Given this list of marker genes CDX2, MET, SOX13, CANT1, HNRNPD, RHOF, CTSE, USP3-AS1, SPAG9, ADAMTS5, USH1C, TNNC1, KLK6, SFXN3, KLK1 (kallikrein 1), FBXO2, MSH5, RBMS2 (RNA binding motif single stranded interacting protein 2), CUL4A, TSPAN8 (NCBI Gene Id 7103), RIT1, KCNQ1, ADORA1 (NCBI Gene Id 134), NAGLU, KIFC2, CLDN3, RAPH1, PACSIN2, MYH14, HSPG2, CDK13, MSLN, SIGIRR, TGFBR2, MYO1A, PPL (periplakin), RNF213, BIN1, FOLR1, IER3, CYSLTR1, PRSS3, OGFR, HECTD1, EPOR, IRF8 (NCBI Gene Id 3394), IFNGR1, NECTIN2, WNK1, ZNF814, ZFPM1, LIMK1, BOLA1, DDC, ID1, ARHGAP26, VASP, MSTN, CHRM1, UBE2G2, MLXIP, KLF13, SHB, CDK18, NASP, RBM5, PAPSS2, CAMK2G (calcium/calmodulin dependent protein kinase II gamma), MYO18A, PRSS8, DAPP1, KRT13, CCL15, ARRB2, ATRX, SEMA4G, SOX9, VSIR, DMPK, PGF, ITGB4, GSE1, EVI2A, ARL4C (ADP ribosylation factor like GTPase 4C), POU3F1, STK17B, EREG, RNU6-37P, KLF2, SULT1A3, RRBP1, TNFSF15, FSCN1, MED6, CLDN2, SRPK2, HOXB5, PRLR (NCBI Gene Id 5618), AREG, ASCL2, SULT1A1, CNOT4, RAB25, DGKD, VDR, PLAAT3, MMP15, DUSP6, SPEN, CLDN4, CBL, MAGI1, CACNA1I, HTATIP2, NR4A1, PXN, CEBPA, SLC6A20, HLA-DRB1, MYLK, MINK1, TNFRSF21, VIL1, FLNB, TNS4, NUMA1, PIP5K1A, NFAT5, ZNF44 (zinc finger protein 44), ARID5B, CLOCK, ENC1, BCAM, SULT1A2, AHNAK, KRT18, FN1, RAB27B, SPG7, ZNF175, VEGFA, SEZ6L2, GDA, PIP5K1B, TNFRSF1B, MDM4, MKLN1, TNFRSF25, ARID1B, PIK3CA, PCDH1, GAA, LGALS4, MYOF, CACUL1, IRF9, EPB41L2, C9orf152, ITGB5, TIMP3, here is a description of the gene set: species: Homo sapiens from publication Rodrigues S, De Wever O, Bruyneel E, Rooney RJ, Gespach C (PMID 17334389) Deleted in colon cancer (DCC) and UNC5 function as netrin dependence receptors by inducing apoptosis in the absence of their ligand and accordingly were recently designated as putative conditional tumor suppressors. Herein, we determined whether netrin-1 and its receptors are implicated in cancer cell invasion and tumor progression. Expression of DCC, UNC5 and adenosine A2B-receptors (A2B-Rs) was investigated by reverse transcription polymerase chain reaction in human colon cancer cells. The impact of DCC restitution and netrin-1 was evaluated on collagen type I invasion, tumor growth and metastasis in nude mice, cancer cell survival and gene expression profiling. Flow cytometry, poly(ADP-ribose)polymerase-1 and caspase-8 activation were used to evaluate the impact of DCC on cell death. Both netrin-1 and A2B-R activation induced the invasive phenotype through the Rho-Rho kinase axis in DCC-deficient human colorectal cancer cells. Restitution of wild-type DCC blocked invasion induced by netrin-1, A2B-R agonist and other agents. Ectopic expression of netrin-1 led to increased growth of human colon tumor xenografts in athymic mice. Conversely, introduction of wt-DCC in kidney MDCKts.src-ggl cells strongly inhibited metastasis in lymph nodes and lungs and increased sensitivity to apoptosis in hypoxia. DNA microarrays revealed that netrin and DCC had common and divergent impacts on gene expression linked to cell cycle, survival, surface signaling and adhesion. Our findings underscore that netrin is a potent invasion and tumor growth-promoting agent and that DCC is a metastasis suppressor gene targeting both proinvasive and survival pathways in a cumulative manner. Genes down-regulated in HCT8/S11 cells (colon cancer) engineered to stably express NTN1 off a plasmid vector. Human Gene Set: RODRIGUES_NTN1_TARGETS_DN